The following is a description of a gene set: from publication Chen Y, Wang X (PMID 31504780) studied in species Homo sapiens Human Gene Set: MIR1249_5P Genes predicted to be targets of miRBase v22 microRNA hsa-miR-1249-5p in miRDB v6.0 with MirTarget v4 prediction scores > 80 (high confidence targets)., and this is the list of marker genes: SH3PXD2A, CTPS2, RPA1, ADAM12, SLC24A2 (solute carrier family 24 member 2), PDE1A, ABCG4, RHOC, IRF2BP1, SMPD3, RAB12, RUNX3, HEBP2, ANKRD52 (NCBI Gene Id 283373, ankyrin repeat domain 52), RAB30, TOM1L2, DTNB, RNASE13, LENG8, CASQ1 (calsequestrin 1), ZDHHC9, C5AR1, NALF2, SFMBT1, LILRA1, SIPA1L1, VWC2, SLC1A5, STMN1, ZIC4, CYB561D1, TNRC6B, C1orf198, CUL4A, VSTM2B, MYH9, F9, SUPT5H, BRWD3, ATP1B2, SREBF2, PIGR, MEX3A, TFCP2L1, E2F1, UBE4B, TFDP2, KCTD2, PIANP, ATRX, C20orf96, PI4KB, DSCAML1 (DS cell adhesion molecule like 1), SEMA5A, GIT1, RIMS3, MROH9, FARP1 (FERM, ARH/RhoGEF and pleckstrin domain protein 1), IMPDH1, PITPNM3 (NCBI Gene Id 83394), ADCY7, YBX2, SMARCC2, MVB12B, SLC9A9, NKD1, COP1, KCNIP3, IQSEC3 (IQ motif and Sec7 domain ArfGEF 3), LASP1, FCGR1BP, PLEKHO2, UBE2D3, AUTS2, KCNC1, DNM1, CDC27, CSN2, WDTC1, INO80D, PLXNA4 (NCBI Gene Id 91584), BCR, RAPGEF1, HMGN4, UBQLN4 (ubiquilin 4), SLC8A2, GPATCH2L, GNAO1, NACC2, CNNM3, NRP2, PACS1, NFAT5, FMNL3, ITGA10, NIBAN3, NOVA2, COLCA1, ADD1, EYA3, TNNI1, PARD3B, TENM4, STEAP3, GATA4, CD200R1, MAP3K9, VAX1, NPLOC4, PDE4A, FILIP1L (filamin A interacting protein 1 like), KCNE4, DUSP4, CSDE1 (cold shock domain containing E1), SHC3, PRR12, CCDC34, CLIC5, NFIX, ZBTB7C, GFAP, SSH1, KLHDC8A, RETREG1, SLC7A5, NIBAN2, CDH26, ULK2, ARHGAP6, SPRY4 (NCBI Gene Id 81848), KSR2, ZNF703, INO80C, POLR2F, TAPBP, CD3E, PSME3, XYLB, ZNF333, CFL1, RORA, IL17REL, TMEM184B, SPRR4, SYP, GSG1L, RPGRIP1L, SYN2 (NCBI Gene Id 6854), NPTXR (NCBI Gene Id 23467), CD300LD-AS1, PDX1, C1orf210, DYRK2, AKT1, ATXN2L, WIPF3, ZNF827 (NCBI Gene Id 152485), PSMB2, LPO, AR, FNDC5, WIPF1, PAQR4, BCL9L, MTCL2, SMARCD1, ITPRID2, TP53INP2, IL17F, SLC25A20, RABGEF1, LZTS1, POU3F4, RAB11FIP5, ISCA2, EDC3, NRN1 (NCBI Gene Id 51299), ZMIZ1, IL2RG, POU2AF1, UCP2, SDK1, KCTD12, OSER1, SYNGAP1, PHYHIP, S100A16, ZFP64, ABTB1, NDUFA4, ARID3B, INKA2, CDC42BPA, AAK1, SH2B3, F12, AP1S1, SDC3, ARK2N